The following is a description of a gene set: studied in species Homo sapiens The appearance of interferon-alpha due to biosynthesis or secretion following a cellular stimulus, resulting in an increase in its intracellular or extracellular levels. Human Gene Set: GOBP_INTERFERON_ALPHA_PRODUCTION, and this is the list of marker genes: DHX36, CHUK, NMI, DHX9, TBK1, TLR4, PTPRS, ZC3HAV1, TLR3 (NCBI Gene Id 7098), NMBR, DDX3X, TRIM65, IRF5, MMP12, HMGB1, NMB, HAVCR2, STAT1, MAVS, IRF7, TLR7, HSPD1 (NCBI Gene Id 56733), IRF3, TLR9, IFIH1, RIPK2, LILRA4, TLR8, IL10, RIGI, NLRC3, SETD2